Given this list of marker genes Enam, Dspp, Bcor, Nectin1, Aspn, Tfap2a, Itgb6, Cnnm4, Tbx1, Rogdi, Fam20a, Amtn, Dmp1, Fam20c, Tcirg1, Stim1, Amelx, Alpl, Wnt6, Odaph, Msx2, Foxo1, Tspear, Hacd1, Enpp1, Tgfb1 (transforming growth factor, beta 1), Slc4a2, Wdr72, Ank, Dicer1, Col1a1, Fgfr1, Sp7, Wls, Ppara, Cftr, here is a description of the gene set: Mouse Gene Set: GOBP_TOOTH_MINERALIZATION studied in species Mus musculus The process in which calcium salts are deposited into calcareous tooth structures such as dental enamel, dentin and cementum.